Given this list of marker genes Slc29a1, Slc18a3, Slc22a3, Slc17a8, Slc29a3, Slc17a6, Slc29a4, Slc28a2, Slc28a2b, Slc6a4, Slc22a2, Slc29a2, Slc17a7, Slc22a1, Slc6a2, Cplx3, Slc6a3, Slc22a4, here is a description of the gene set: studied in species Mus musculus Mouse Gene Set: GOMF_NEUROTRANSMITTER_TRANSMEMBRANE_TRANSPORTER_ACTIVITY Enables the directed movement of a neurotransmitter into, out of or within a cell, or between cells. Neurotransmitters are any chemical substance that is capable of transmitting (or inhibiting the transmission of) a nerve impulse from a neuron to another cell.